Given this list of marker genes ATF4, EIF2AK3, DDIT3, PSEN1, EIF2S1, here is a description of the gene set: Human Gene Set: KEGG_MEDICUS_VARIANT_MUTATION_CAUSED_ABERRANT_PSEN1_TO_PERK_ATF4_SIGNALING_PATHWAY Pathway Definition from KEGG: PSEN1* -| EIF2AK3 -> EIF2S1 -> ATF4 => DDIT3 Mutation-caused aberrant PSEN1 to PERK-ATF4 signaling pathway. Pathway ID: N01010. Pathway type: Variant. Pathway class: nt06534 Unfolded protein response. studied in species Homo sapiens